The following is a description of a gene set: species: Homo sapiens Human Gene Set: GOMF_ARYL_HYDROCARBON_RECEPTOR_BINDING Binding to an aryl hydrocarbon receptor., and this is the list of marker genes: AIP, ARNT2, TBP, ARNT, NCOA2, TAF4, TAF6, BMAL1